Given this list of marker genes SNW1, KAT2A, H2AJ, TNRC6B, NOTCH2NLA, MAML3, H2BC17, H2BC4, H2AZ2, TNRC6C, MIR34C, NOTCH2NLR, MIR302A, MIR449B, H2AB1, MIR449C, MIR34A, H2BC9, H3C15, H2BC1, NOTCH1, TP53, NOTCH2NLC, NOTCH2, H2BC14, KAT2B, H2BC12, AGO1, H2BC13, H2BC5, MIR200C, H2AC14, AGO3, H3C1, SIRT6, RBPJ, H2BC26, AGO4, H2AC20, H2BC11, MIR200B, AGO2, H4C1, MIR206, TFDP2, H2BC12L, H2BC3, H2BC15, MIR449A, H2AC7, H3-3A, CREBBP, H2BC21, TFDP1, MAML2, CCND1, ELF3, RUNX1, MOV10 (NCBI Gene Id 57723), TNRC6A, NOTCH2NLB, ELANE, E2F1, MAMLD1, H2AC4, EP300, NOTCH3, H2AX, MAML1, H2AC6, JUN, MIR181C, H2AC18, MIR34B, PRKCI, E2F3, NOTCH4, MIR150, here is a description of the gene set: Reactome Pathway: Pre-NOTCH Transcription and Translation part of: Pre-NOTCH Expression and Processing species: Homo sapiens <p>In humans, the NOTCH protein family has four members: NOTCH1, NOTCH2, NOTCH3 and NOTCH4. NOTCH1 protein was identified first, as the product of a chromosome 9 gene translocated in T-cell acute lymphoblastic leukemia that was homologous to Drosophila Notch. At the same time, rat Notch1 was cloned, followed by cloning of mouse Notch1, named Motch (Del Amo et al. 1992). NOTCH2 protein is the product of a gene on chromosome 1. NOTCH2 expression is differentially regulated during B-cell development. NOTCH2 mutations are a rare cause of Alagille syndrome. NOTCH3 is the product of a gene on chromosome 19. NOTCH3 mutations are the underlying cause of CADASIL, cerebral arteriopathy with subcortical infarcts and leukoencephalopathy. NOTCH4, the last NOTCH protein discovered, is the product of a gene on chromosome 6. </p><p>MicroRNAs play an important negative role in translation and/or stability of NOTCH mRNAs. MicroRNAs miR-34 (miR-34A, miR-34B and mi-R34C), whose transcription is directly induced by the tumor suppressor protein p53 bind and negatively regulate translation of NOTCH1 mRNA and NOTCH2 mRNA. NOTCH1 mRNA translation is also negatively regulated by microRNAs miR-200B and miR-200C, as well as miR-449A, miR-449B and miR-449C. Translation of NOTCH3 mRNA is negatively regulated by microRNAs miR-150 and miR-206. Translation of NOTCH4 mRNA is negatively regulated by microRNAs miR-181C and miR-302A. </p><p>The <i>NOTCH2NL</p> (Notch homolog 2 N-terminal-like) gene family includes four genes, <i>NOTCH2NLA</i> (Notch homolog 2 N-terminal-like A), <i>NOTCH2NLB</i> (Notch homolog 2 N-terminal-like B), <i>NOTCH2NLC</i> (Notch homolog 2 N-terminal-like), and <i>NOTCH2NLR</i> (Notch homolog 2 N-terminal-like R), which originated from the partial duplication of the first four exons and introns of the <i>NOTCH2</i> gene and function to modulate NOTCH signaling.</p><p>Nascent NOTCH peptides are co-translationally targeted to the endoplasmic reticulum for further processing, followed by modification in the Golgi apparatus, before trafficking to the plasma membrane. Endoplasmic reticulum calcium ATPases, positively regulate NOTCH trafficking, possibly by contributing to accurate folding of NOTCH precursors.</p>